Given this list of marker genes CPLX1, ACSBG1, LHFPL2, MIR646HG, HRK, CIB2, RIPK4, TBC1D19, CD8B, DNMBP, ELOVL4, EFNB2, SLAMF1, CALN1, SLC7A3, BCL6, RORC, CD1C, CYP2U1, RMND5A, CD1D (NCBI Gene Id 912), WAKMAR2, RASD1, C3orf52, SH2D1A, LYST, MCTP1, CD8A, here is a description of the gene set: from publication Lee MS, Hanspers K, Barker CS, Korn AP, McCune JM (PMID 15210650) species: Homo sapiens Human Gene Set: LEE_DOUBLE_POLAR_THYMOCYTE Genes enriched in the double polar (DP) thymocyte compared to all other T lymphocyte differentiation stages. To develop a comprehensive catalogue of phenotypic and functional parameters of human CD4(+) T cell differentiation stages, we have performed microarray gene expression profiling on subpopulations of human thymocytes and circulating naive CD4(+) T cells, including CD3(-)CD4(+)CD8(-) intrathymic T progenitor cells, CD3(int)CD4(+)CD8(+) 'double positive' thymocytes, CD3(high)CD4(+)CD8(-) 'single positive' thymocytes, CD3(+)CD4(+)CD8(-) CD45RA(+)CD62L(+) naive T cells from cord blood and CD3(+)CD4(+)CD8(-) CD45RA(+)CD62L(+) naive T cells from adult blood. These subpopulations were sort-purified to >98% purity and their expressed RNAs were analyzed on Affymetrix Human Genome U133 arrays. Comparison of gene expression signals between these subpopulations and with early passage fetal thymic stromal cultures identify: (i) transcripts that are preferentially expressed in human CD4(+) T cell subpopulations and not in thymic stromal cells; (ii) major shifts in gene expression as progenitor T cells mature into progeny; (iii) preferential expression of transcripts at the progenitor cell stage with plausible relevance to the regulation of expansion and differentiation of these cells; and (iv) preferential expression of potential markers of recent thymic emigrants in naive-phenotype CD4(+) T cells from cord blood. Further evaluation of these findings may lead to a better definition of human thymopoiesis as well as to improved approaches to monitor and to augment the function of this important organ of T cell production.